The following is a description of a gene set: Human Gene Set: JIANG_TIP30_TARGETS_UP from publication Jiang C, Pecha J, Hoshino I, Ankrapp D, Xiao H (PMID 17440068) Up-regulated genes in HepG2 cells (liver cancer) overexpressing an oncogenic variant of tumor suppressor TIP30 compared to its wild type form. species: Homo sapiens TIP30 is a tumor suppressor whose expression is altered in human liver, prostate, lung, colon, and breast cancers. Mice lacking TIP30 spontaneously developed hepatocellular carcinomas (HCC) and other tumors at a higher incidence than wild-type mice. Somatic missense mutations in the TIP30 gene were identified in human HCC tissue specimens, which resulted in instability or abnormal cellular distribution of TIP30 protein in cells. Here, we show that TIP30 mutants are able to promote cell growth and invasion and inhibit cisplatin-induced apoptosis in the HCC cell line HepG2 negative for endogenous TIP30. Moreover, one of the TIP30 mutants can dramatically accelerate tumor formation in immunodeficient mice. Analysis of gene expression in HepG2 cells, ectopically expressing either wild-type TIP30 or mutant TIP30, by Affymetrix GeneChip array, real-time quantitative PCR, and Western blotting assays reveals that TIP30 mutants can alter expression of genes involved in the regulation of tumorigenesis. This includes up-regulation of expression of N-cadherin and c-MYC and down-regulation of expression of p53 and E-cadherin. N-cadherin knockdown with small interfering RNA in HepG2 cells expressing mutant TIP30 resulted in a profound reduction in cell viability. Taken together, our data indicate that somatic mutations in the TIP30 gene may abolish its native tumor-suppressor activity and gain oncogenic activities partially through up-regulation of N-cadherin, thereby potentiating the pathogenesis of HCC in patients., and this is the list of marker genes: NDE1, CDH2, MMP3, IGFBP3, LAMB1, IER3, RGCC, CCN1 (NCBI Gene Id 3491), IRS1, WEE1, JAG1, CDK1, DUSP1 (dual specificity phosphatase 1), BCL6, PPP1R2, ARG2, RAD17, TMSB10, IFITM2, STAM2, NFIL3, IGFBP1, CD24, CALCRL, ANXA2, PTTG1, C1GALT1, ENPP1, RAPGEF5, CHST6, FYN, STK26, PPARGC1B, NDC80, MTAP, EEF2, P4HA1 (prolyl 4-hydroxylase subunit alpha 1), RAB1A, VCAN, MALT1, ITGA6, NEDD9, HNMT, AXL, OGA, PSMC6